Given this list of marker genes MFSD4B, SLC2A7, SLC50A1, SLC5A10, SLC2A9 (NCBI Gene Id 56606), SLC45A3, SLC5A9, FGF21, SLC5A1, SLC2A4, SLC5A4, SLC2A2, SLC2A1, SLC2A10 (NCBI Gene Id 81031), SLC2A6, SLC2A3, SLC2A12, SLC2A11, SLC5A2, SLC2A14 (NCBI Gene Id 399494), SLC2A8, here is a description of the gene set: studied in species Homo sapiens Cellular hexose transport Human Gene Set: REACTOME_CELLULAR_HEXOSE_TRANSPORT